The following is a description of a gene set: Reactome Pathway: Negative regulation of FGFR3 signaling studied in species Homo sapiens part of: Signaling by FGFR3 Once activated, the FGFR signaling pathway is regulated by numerous negative feedback mechanisms. These include downregulation of receptors through CBL-mediated ubiquitination and endocytosis, ERK-mediated inhibition of FRS2-tyrosine phosphorylation and the attenuation of ERK signaling through the action of dual-specificity phosphatases, IL17RD/SEF, Sprouty and Spred proteins. A number of these inhibitors are themselves transcriptional targets of the activated FGFR pathway., and this is the list of marker genes: UBC, FGF9, BRAF, RPS27A, PPP2R1A, FGF17, MAPK3, FGF23, GRB2, FGF1, UBB, SRC (NCBI Gene Id 6714), PPP2CB, PTPN11, CBL, FGF5, PPP2CA, FGF16, FRS2, FGF4, UBA52, SPRY2, FGFR3 (fibroblast growth factor receptor 3), MAPK1, FGF2, FGF20, MKNK1, FGF18, FGF8